Given this list of marker genes LIMA1, MYLK, MYH10, MEN1, SEPTIN3, SEPTIN9, SEPTIN8, SVIL, PPP1CC, RDX, ITGB1, MASTL, SEPTIN6, PDXP, NF2, RHOA, SEPTIN1, RACGAP1, WDR73, CEP55 (centrosomal protein 55), HMCN1, SEPTIN2, RAB21, SEPTIN11, SSH1, MAEA, RAB11A, PKN1, STAMBP, DIAPH3, SEPTIN10, OR2A4, RAB11FIP3, KIF20A, ECT2, PLEKHG6 (pleckstrin homology and RhoGEF domain containing G6), PLCD3, ICAM2, RHOB, KATNBL1, SEPTIN7, SEPTIN12, HTR3A, FSD1, RALA, SEPTIN14 (septin 14), SEPTIN4, SPIRE1, MYH9, ARF6, RAB11FIP4, PSD2, NDE1, PITPNM1, SEPTIN5, DCTN3, PKN2, PLK4 (polo like kinase 4), PSTPIP1, RTKN, PSD4, ANKRD45, ZFYVE19, PSD, HMCN2, RHOC, ANLN, GTF2B, SPIRE2, here is a description of the gene set: The eventual plane of cell division (also known as cell cleavage or cytokinesis) in a dividing cell. In Eukaryotes, the cleavage apparatus, composed of septin structures and the actomyosin contractile ring, forms along this plane, and the mitotic, or meiotic, spindle is aligned perpendicular to the division plane. In bacteria, the cell division site is generally located at mid-cell and is the site at which the cytoskeletal structure, the Z-ring, assembles. Human Gene Set: GOCC_CELL_DIVISION_SITE species: Homo sapiens